Given this list of marker genes St3gal4, 6430550D23Rik, St3gal3, St3gal6, St3gal2, St3gal1, here is a description of the gene set: Catalysis of the reaction: CMP-N-acetylneuraminate + beta-D-galactosyl-(1->3)-N-acetyl-alpha-D-galactosaminyl-R = CMP + alpha-N-acetylneuraminyl-(2->3)-beta-D-galactosyl-(1->3)-N-acetyl-alpha-D-galactosaminyl-R. Mouse Gene Set: GOMF_BETA_GALACTOSIDE_CMP_ALPHA_2_3_SIALYLTRANSFERASE_ACTIVITY species: Mus musculus